The following is a description of a gene set: The chemical reactions and pathways resulting in the breakdown of a mitochondrial protein. This process is necessary to maintain the healthy state of mitochondria and is thought to occur via the induction of an intramitochondrial lysosome-like organelle that acts to eliminate the damaged oxidised mitochondrial proteins without destroying the mitochondrial structure. studied in species Mus musculus Mouse Gene Set: GOBP_MITOCHONDRIAL_PROTEIN_CATABOLIC_PROCESS, and this is the list of marker genes: Proca1, Bnip3, Spata18, Bnip3l-ps, Bnip3l, Yme1l1, Pisd, Afg1l